The following is a description of a gene set: studied in species Mus musculus The chemical reactions and pathways resulting in the formation of phosphatidic acid, any derivative of glycerol phosphate in which both the remaining hydroxyl groups of the glycerol moiety are esterified with fatty acids. Mouse Gene Set: GOBP_PHOSPHATIDIC_ACID_BIOSYNTHETIC_PROCESS, and this is the list of marker genes: Dgkk, Bscl2, Abhd8, Slc27a1, Dgki, Agpat2 (1-acylglycerol-3-phosphate O-acyltransferase 2), Sh3glb1, Pld2, Abhd4, Dgkg (NCBI Gene Id 73000), Pnpla3, Agpat1, Dgke, Dgkd, Dgkq, Gpam, Dgka, Nr1h4, Dgkb, Pld1, Abhd5, Dgkz, Gpat2, Dgkh